Given this list of marker genes MDFI, LEF1, HES1, ZC4H2, CEBPG, H1-0, TRIM6, TNKS, RSF1, ILRUN, SUMO3, MMP9, NEUROD1, TWIST1, HMGA2, HEY2, HJURP, BCL3, HMGB1, GATA1, PLAUR, NME1, POU4F1, GTF2B (general transcription factor IIB), RB1, NIBAN2, IFNG, CSNK2B, IFI16, TFAP4, SUMO4, GATA3, RNF220, DAZAP2, ZNF593, NFIB, FOXC1, EGF, SUMO1, PYHIN1, DOT1L, TXN, E2F1, SOX11, CPNE1, GZMA (granzyme A), SIRT2, PSEN1 (presenilin 1), HAND2, POU4F2, ZBTB7A, PINX1, IGF1, SKI, JUN, SMO, NSD1, EDF1, here is a description of the gene set: Human Gene Set: GOBP_REGULATION_OF_DNA_BINDING Any process that modulates the frequency, rate or extent of DNA binding. DNA binding is any process in which a gene product interacts selectively with DNA (deoxyribonucleic acid). species: Homo sapiens